Given this list of marker genes Stard3, Dgkq, Egr1, Scp2, Ppargc1a, here is a description of the gene set: studied in species Mus musculus Mouse Gene Set: GOBP_PROGESTERONE_BIOSYNTHETIC_PROCESS The chemical reactions and pathways resulting in the formation of progesterone, a steroid hormone produced in the ovary which prepares and maintains the uterus for pregnancy. Also found in plants.